Given this list of marker genes IL13RA1, LMO3, PGF, FGF4, HOXA6, ITGB8, KLF7, STRIP1, NFIA, FBRS, BRSK1, DNAJB4, GPR119, IKZF2, MYLK, NEUROD2, ZNF593, FOXI2, IER5L, BMF, FER1L6-AS1, IL1RAPL1, MYCL, PPM1L (NCBI Gene Id 151742), EMP1, TFAP2A, NSD1, MTSS1, TGM4, GBA2, ACACA, IGSF22, GNGT2, SEZ6, FBLN2, ESM1, CCN3, B2M (beta-2-microglobulin), HOXA3, PTCHD1, EPHA7, ROCK2 (NCBI Gene Id 9475), HOXD3, HOXB6, BCL11A, APLN, TUSC2, KMT2E, here is a description of the gene set: studied in species Homo sapiens Genes having at least one occurrence of the motif CRSCTGTBBNNTTTGGCACBSNGCCARCH in the regions spanning 4 kb centered on their transcription starting sites. This matches the NF1 transcription factor binding site V$MYOGNF1_01 (v7.4 TRANSFAC). Human Gene Set: MYOGNF1_01